Given this list of marker genes Ak8, Ak9, Pals1, Cmpk1, Ak2 (NCBI Gene Id 52171), Ak4, Cmpk2, Lrguk, Ak7, Ak1, Guk1 (guanylate kinase 1), Ak5, Ak3, Gm17949, Ak6, Pals2, here is a description of the gene set: species: Mus musculus Catalysis of the reaction: a ribonucleoside 5'-phosphate + ATP = a ribonucleoside 5'-diphosphate + ADP. Mouse Gene Set: GOMF_NUCLEOSIDE_MONOPHOSPHATE_KINASE_ACTIVITY